The following is a description of a gene set: studied in species Homo sapiens Human Gene Set: REACTOME_FRS_MEDIATED_FGFR1_SIGNALING FRS-mediated FGFR1 signaling, and this is the list of marker genes: FGF9, FGF22, KL, FGF23, FGF2, FGF10, PTPN11, HRAS, SOS1, FGF6, FGF8, FGF3, FGF5, FGF4, KRAS, FGFR1, FGF17, FGF1, NRAS, GRB2, FRS2, FGF20, FRS3